Given this list of marker genes GGT6, ALOX5AP (arachidonate 5-lipoxygenase activating protein), GGT7, GGT5, GGTA1, MGST2 (microsomal glutathione S-transferase 2), MGST3, PLA2G5, PRG3, PLA2G1B, GGT3P, GGTLC2, LTA4H, GGTLC3, SYK, LTC4S, GGT1, ALOX5, PLA2G4A, GGT2P, GGTLC1, here is a description of the gene set: Human Gene Set: GOBP_LEUKOTRIENE_BIOSYNTHETIC_PROCESS species: Homo sapiens The chemical reactions and pathways resulting in the formation of leukotriene, a pharmacologically active substance derived from a polyunsaturated fatty acid, such as arachidonic acid.